Given this list of marker genes Psma7, Psmc4, Psmd7, Psma5, Psmd13, Psmb7, Psma4 (NCBI Gene Id 26441), Psmc6, Psmb6, Psmc5, Psmd12, Trp53, Psmd6, Psmb4, Psma2, Ubb, Rps27a, Psmc3, Psma1, Psma6, Psmc1, Psma3, Psmb5, Psmc2, Psmd1, here is a description of the gene set: This event has been computationally inferred from an event that has been demonstrated in another species.<p>The inference is based on the homology mapping from PANTHER. Briefly, reactions for which all involved PhysicalEntities (in input, output and catalyst) have a mapped orthologue/paralogue (for complexes at least 75% of components must have a mapping) are inferred to the other species. studied in species Mus musculus electronically inferred by orthology from the curated human pathway part of: Stabilization of p53 Reactome Pathway: Autodegradation of the E3 ubiquitin ligase COP1